Given this list of marker genes Casp1, Gsdmd, Il1a, Rela, Nfkb1, Nfkb2, Ctsg, here is a description of the gene set: This event has been computationally inferred from an event that has been demonstrated in another species.<p>The inference is based on the homology mapping from PANTHER. Briefly, reactions for which all involved PhysicalEntities (in input, output and catalyst) have a mapped orthologue/paralogue (for complexes at least 75% of components must have a mapping) are inferred to the other species. electronically inferred by orthology from the curated human pathway Reactome Pathway: Interleukin-1 processing species: Mus musculus part of: Interleukin-1 family signaling